Given this list of marker genes OSMR, COL3A1, ADGRL4, TNC, PLD1, CCL21, RASSF4, SERPING1 (serpin family G member 1), C4A, GPNMB, COL4A2, DEPP1, PMP22, NR1H3, SAMD9L, CYP1B1, TNS1, FCHO2, EMILIN1, DCLK1, WWTR1, CMKLR1, IGFBP5, CDH11, GABBR1, SULF1, RSPO3, C1QB, COL6A1, SERPINH1, SLAMF8, CLU, PTGDS, CCL19, FLRT2, CETP, RBPMS, LAMB1, TANC1, ENG, A2M, KCTD12, KCNMA1, SEPTIN10, RHOBTB3, COL15A1, PPIC, GASK1B, PDLIM5, SLC40A1, ENPP2, HSPG2, LIFR, ITGA9, SPARCL1, TNS3, MYLK, RGL1, RND3, ADAMTS1, ACKR1, DOCK4, TMEM176B, P2RY13, ABCC3, RRAS, ZNF226, SPARC, NFIB, DPYSL3, HSPB8, RGS5, FSTL1, CYP26B1, TEAD2, C7, PDPN, IRAK3 (interleukin 1 receptor associated kinase 3), SMOC2, NR2F2, THY1, EMCN, NAGK, COL1A2, CTHRC1 (NCBI Gene Id 115908), GUCY1B1, MXRA5, NEXN, RPE, GJA1, CLMP, KCNJ10, ADGRF5, CHI3L1, FAM20A, MIR34AHG, CTTNBP2NL, CALD1, TLR4, LAMA4, ANTXR1, ARHGAP42, CYBRD1, PDGFRA, RARRES2 (NCBI Gene Id 5919), ANK2, FAM114A1, TAGLN, FUCA1, SPRED1, FERMT2, GPRC5B, LPAR1, HNMT, APOE (NCBI Gene Id 99), CCL2, RAB13, DHRS7B, PGF, IFI27, MIR1245A, ARHGAP29, COX7A1, CCN4, PAPSS2, CSRP2, IDH1 (isocitrate dehydrogenase (NADP(+)) 1), TDO2 (NCBI Gene Id 6999), EPHX1, IL18, CYP27A1, FBN1 (NCBI Gene Id 7470), LOXL1, C1QC, MMP9, ANKRD29, CD63, PRRX1, CDH5, ACVRL1, ADAMDEC1, ARHGEF10, ADRA2A, TRIM47, C3, ITPRIPL2, CFB, NPL, FN1, WDFY3, ACTA2, MFAP4, CCL14, PCOLCE, VWF, CYFIP1, GJC1, MYL9 (NCBI Gene Id 10398), C1QA, GUCY1A1, CCDC80, PARVA, C2, CXCL10, WLS, NNMT, VCAM1, TMEM176A (NCBI Gene Id 96710), RBP5, TCIM, YAP1, LUM, CFH, CARMN, SLCO2B1, PLA2G2D, SLC1A3, S1PR3, CP, ATOX1, COL1A1, DAB2, FAM107A, COL8A2, C1R, CTSC (cathepsin C), TMEM163 (NCBI Gene Id 81615), CAV2, COL4A1, APOC1, ASPM, CCDC102B, CD93, RAI14, DDR2, LAMC1, MARCKS, ADAMTS9, PLPP3, CTSL, ABI3BP, TJP1, IGFBP7, CAVIN1, IL33, TPM1, COL12A1, CXCL9, C1S, PLA2G4C, CXCL12, here is a description of the gene set: studied in species Homo sapiens from publication Piccaluga PP, Agostinelli C, Califano A, Carbone A, Fantoni L, Ferrari S, Gazzola A, Gloghini A, Righi S, Rossi M, Tagliafico E, Zinzani PL, Zupo S, Baccarani M, Pileri SA (PMID 18006812) Human Gene Set: PICCALUGA_ANGIOIMMUNOBLASTIC_LYMPHOMA_UP Angioimmunoblastic lymphoma (AILT) is the second most common subtype of peripheral T-cell lymphoma (PTCL) and is characterized by dismal prognosis. Thus far, only a few studies have dealt with its molecular pathogenesis. We performed gene expression profile (GEP) analysis of six AILT, six anaplastic large cell lymphomas (ALCL), 28 PTCL-unspecified (PTCL/U), and 20 samples of normal T lymphocytes (including CD4(+), CD8(+), and activated and resting subpopulations), aiming to (a) assess the relationship of AILT with other PTCLs, (b) establish the relationship between AILT and normal T-cell subsets, and (c) recognize the cellular programs deregulated in AILT possibly looking for novel potential therapeutic targets. First, we found that AILT and other PTCLs have rather similar GEP, possibly sharing common oncogenic pathways. Second, we found that AILTs are closer to activated CD4(+), rather than to resting or CD8(+) lymphocytes. Furthermore, we found that the molecular signature of follicular T helper cells was significantly overexpressed in AILT, reinforcing the idea that AILT may arise from such cellular counterpart. Finally, we identified several genes deregulated in AILT, including PDGFRA, REL, and VEGF. The expression of several molecules was then studied by immunohistochemistry on tissue microarrays containing 45 independent AILT cases. Notably, we found that the vascular endothelial growth factor (VEGF) was expressed not only by reactive cells, but also by neoplastic cells, and that nuclear factor-kappaB (NF-kappaB) activation is uncommon in AILT, as suggested by frequent exclusively cytoplasmic c-REL localization. Our study provides new relevant information on AILT biology and new candidates for possible therapeutic targets such as PDGFRA (platelet-derived growth factor alpha) and VEGF. Up-regulated genes in angioimmunoblastic lymphoma (AILT) compared to normal T lymphocytes.